The following is a description of a gene set: Human Gene Set: REACTOME_LAGGING_STRAND_SYNTHESIS studied in species Homo sapiens Lagging Strand Synthesis, and this is the list of marker genes: POLA2, POLD1, LIG1, POLD4, RPA1, FEN1, RFC3, POLD3, RPA2 (NCBI Gene Id 6118), DNA2, RFC2, RFC1, PRIM1, PCNA, RFC5, POLA1, POLD2, RPA3, RFC4, PRIM2